The following is a description of a gene set: DSCAM (Down syndrome cell adhesion molecule) is one of the members of the Ig superfamily CAMs with a domain architecture comprising 10 Ig domains, 6 fibronectin type III (FN) repeats, a single transmembrane and a C terminal cytoplasmic domain. DSCAM is implicated in Down syndrome (DS) due to the chromosomal location of the DSCAM gene, but no evidence supports a direct involvement of DSCAM with DS. It likely functions as a cell surface receptor mediating axon pathfinding. Besides these important implications, little is known about the physiological function or the molecular mechanism of DSCAM signal transduction in mammalian systems. A closely related DSCAM paralogue Down syndrome cell adhesion moleculelike protein 1 (DSCAML1) is present in humans. Both these proteins are involved in homophilic intercellular interactions. Reactome Pathway: DSCAM interactions part of: Netrin-1 signaling studied in species Homo sapiens, and this is the list of marker genes: DSCAM, DCC, NTN1, DSCAML1